Given this list of marker genes FKBP1B, SCN1B, SCN1A, NTRK3, SCN9A, NTRK2, CACNB4, CLDN19, CLCN1, NRCAM (NCBI Gene Id 4897), CNTNAP1, ATP1A2, here is a description of the gene set: Human Gene Set: GOBP_ACTION_POTENTIAL_PROPAGATION The propagation of an action potential along the plane of an excitable membrane. Action potentials typically propagate once triggered because the depolarization of adjacent membrane regions due to an action potential crosses the firing threshold. studied in species Homo sapiens